Given this list of marker genes PYGL, AKR1C3, VDR, AKR1C2, NAPEPLD, AKR1C1, AKR1C4, PLA2G1B, NR1H4, here is a description of the gene set: studied in species Homo sapiens Human Gene Set: GOMF_BILE_ACID_BINDING Binding to a bile acid, a steroid carboxylic acids occurring in bile.